Given this list of marker genes CYP11A1, INSIG1, IL1B, CREB1, SLC2A8, SH2B2, RANGAP1, SOS1, INSRR (NCBI Gene Id 3645), UMODL1, AHSG, GPR21, INSR, JAK3, GRIA1, BLVRB, LPIN1, APPL2, NCL, PAK1, FER, PIP4K2A, NR4A3, MIR1271, WNT1, SP1, PLA2G2A (phospholipase A2 group IIA), BCAR1, CPEB1, SRC, TNS2, FBP1, CACNA2D3, NAMPT, GPLD1, TOP1, KBTBD2, GNRHR2, FAT1, SESN3, MZB1, NCOA5, NFKB1, LYN, MDM2, LEP (leptin), ACE, MGARP, MIR143, NDEL1, ACTN2, NR4A2, SCNN1D, SHC1, APPL1, INPP5K, ZBTB7B, SELENOS, TRIM72, TYK2, CA2, GDF15, DENND4C, AP3S1, PRKCB, HRAS, LHCGR, BGLAP, SNX5, CRHR2, CSK, GNAS (GNAS complex locus), GSK3B, FUT1, LPIN3, SERPINA12, NONO, MIR195, FUT7, VWA2, TRARG1, SRD5A1, GHR, SLC27A4, MAPK1, MTCL2, SLC22A12, AGT, RAB10, ECHDC3, SREBF1, PNPLA3, SORBS1, SCNN1G, PRKD1, MIR15B, CDC6, GRB7, POU4F2, CUL7, SOS2, AKT2, GPR173, MAPK3 (mitogen-activated protein kinase 3), AHCYL1, COL6A1, CCNA2, PTPN1, IRS1, GCGR, TBC1D4, GHSR, STAT6, HNF4A, STAT1, POR, LONP1, SLC27A1, CRHR1, EPRS1, PID1, EDN1, ZNF106, IDE, NUCKS1, GRB10, GRB2, RAF1, PRKCA, PLCB1, SGCB, INSIG2, NFE2L2, FBXW8, FFAR3, SOCS1 (NCBI Gene Id 8651), AKT1, PPARG, SLC26A6, SLC25A33, NCK1, EEF2K, IGF1R, ZNF592, RELA, PLA2G1B, GAB1, HSF1 (NCBI Gene Id 642255), NCOA1, HDAC5, GSTP1, PRKAA1, SLC9A1, ZFP36L1, CRK, SIK2, CSH1, MSTN, SLC2A4, YWHAG, LPIN2, MYO5A, NKX6-1, CEACAM1, PHIP, ERRFI1, PXN, IGF1, ADIPOQ, SLC39A14, PIK3R3, GPER1, MAP3K7, STAT5B, JAK1, ATP2B1, AGTR2, FOXO4, TSHR, RPS6KB1, CFL1, INHBB, GH1, GCK, AGTRAP, CYP11B2, EIF4EBP2, GSK3A, SLC30A10, UCP2, CAPN10, ITGB3, ALAS1, GCLC, PKLR, NR1H4, STAT5A, TRIB3, RB1, CAMK2A, SCNN1B, MIR145, ROCK1, CAV2, G6PC1, GLP1R, C1QTNF12, PTPRE, OGT, PDK2, SHOC2, CYP11B1, TSC2, SOCS7, KAT2B, XBP1, ADIPOR1, GRB14, PTPN2, INS, PRKCZ, FOS, IGFBP1, VAMP2 (vesicle associated membrane protein 2), PCK2, ERFE, CRHBP, CPEB2, USO1, NPPA, PRKCQ, C2CD5, ASS1, CUL3, LEPROTL1, FOXC2, CTSD, MAPKAP1, RAP1GDS1, STAT3, PCSK9 (proprotein convertase subtilisin/kexin type 9), HMGCS2, RAC1, RAB8A, GNRHR, STXBP4, CFLAR, AGTR1, FBN1, RAB13, APC, CSHL1, ADCY8, DDR2, IRS4, ROCK2, IRS2, DNAI1, SCNN1A, ENPP1, EDNRA, BAIAP2, MTOR, PPP3CA, SIRT1, PKM (pyruvate kinase M1/2), PDK4, RBX1, SOCS3, KANK1, PIP4K2C, MYO1C, MAP1B (NCBI Gene Id 4131), BCAR3, INHBA, RPS6KB2, JAK2, PRKCD, ADCY6, FAM114A1, CSF2RA, RBM4, MIR107, PTK2, GHRL, PIK3R2, CAV1, OSBPL8, CSRP3, MAS1, SOCS2, PCK1, FYN, PIK3CA, SYAP1, FOXO1, PIK3R1, PDE3B, GCG, CSH2, SORL1, LEPROT, IGF2, SRSF5, PIP4K2B (phosphatidylinositol-5-phosphate 4-kinase type 2 beta), PARP1, PRKCI, PDPK1, MBD5, CYBA, RHOQ, PTPRJ, CPS1, PTPN11, RAB31, MIR103A1, OTOP1, TGFB1, WDTC1, PIK3C2A, PRKAR1A, NR4A1, PRKACA, SMARCC1, ZDHHC7, USF1, GLP2R, HDAC9, RARRES2 (retinoic acid receptor responder 2), NCOA2, GH2, GHRHR, GOT1, PRKDC, GKAP1, here is a description of the gene set: studied in species Homo sapiens Any process that results in a change in state or activity of a cell (in terms of movement, secretion, enzyme production, gene expression, etc.) as a result of a peptide hormone stimulus. A peptide hormone is any of a class of peptides that are secreted into the blood stream and have endocrine functions in living animals. Human Gene Set: GOBP_CELLULAR_RESPONSE_TO_PEPTIDE_HORMONE_STIMULUS